Given this list of marker genes NEFL (neurofilament light chain), GIGYF2, ALDH1A3, CLN8, BCR, CNTNAP1, GPR88, HERC1, TPP1 (NCBI Gene Id 727719), HMX3, NKX6-2, FOXS1, BLOC1S4, EI24, JPH4, NR4A3, MYO7A, SHANK3, DCANP1, REST, MYH10, ADCY5 (adenylate cyclase 5), POU4F3, NRXN1, GM2A, ANKFN1, ABL1, CWH43, TNR, NBN, CLN3, GAA, ZNF212, JPH3, AARS1, USH1G, CAMTA1, CDH23, HEXA, TIFAB, USH1C, DLG4, SHANK1, RAC3, POU4F2, VPS13A, PDE8B, PAFAH1B1 (platelet activating factor acetylhydrolase 1b regulatory subunit 1), SLC1A3, ELP6, NLGN2, HEXB, NEUROG1, IGLON5, IGDCC3, CLRN1, GRIN2C, POU4F1, PCDH15, here is a description of the gene set: Human Gene Set: GOBP_NEUROMUSCULAR_PROCESS_CONTROLLING_BALANCE Any process that an organism uses to control its balance, the orientation of the organism (or the head of the organism) in relation to the source of gravity. In humans and animals, balance is perceived through visual cues, the labyrinth system of the inner ears and information from skin pressure receptors and muscle and joint receptors. studied in species Homo sapiens